Given this list of marker genes Mdm2, Gstp2, Ppargc1a, Htr1b, Jak2, Sod2, Tgfb3, Drd4, Frs2, Grk2, Gnai2, Ndrg2, Mir124a-1hg, Adipoq, Pparg, Apln, Agtr1a, Efemp2, Map3k5, Camk2d, Fgf9, Rhoa, Fgfr2, Tnf, Gja1, Gna12, P2ry6, Ern1, Cdkn1b, Mir504, Edn1, Nqo2, Ddit3, Fgf2, Pdgfb, Pdcd4, Dbh, Mfn2, Park7, Pak1, Src, Gstp1, Ddr2, Foxj2, Timp3, Pten (phosphatase and tensin homolog), Igf1, Jun, Rbm10, Tpm1, Nox1, Bmpr1a, S1pr2, Dnmt1, Igfbp5, Mef2c, Nf1, Prkg1, Cdkn1a, Mmp2, Hpgd, Agt, Calcrl, Mmp9, Tert, Myocd, Gnai3, Cnn1, Tafa5, Il10, Spon2 (NCBI Gene Id 76474), Hmox1, Enpp1, Xbp1, Mef2d, Ddx39b, Cav1, Rgs5, Map3k7, Ldlrap1, Adamts1, Poldip2, Nr4a3, Gper1 (G protein-coupled estrogen receptor 1), Gna13, here is a description of the gene set: The multiplication or reproduction of vascular smooth muscle cells, resulting in the expansion of a cell population. A vascular smooth muscle cell is a non-striated, elongated, spindle-shaped cell found lining the blood vessels. Mouse Gene Set: GOBP_VASCULAR_ASSOCIATED_SMOOTH_MUSCLE_CELL_PROLIFERATION studied in species Mus musculus